Given this list of marker genes Klc1, Tlr3, Cbl, Smarcd1, Ptprj, Olfml3, Npepps, Tfdp2, Rbm47, Fam241a, Hsdl1, Lamtor1, Myo9a, Snai2, Tbx20, Oaz1, Fut8, Pkm, Xxylt1, Srf, Ddx24, Rtraf, Atp2b2, Grhl2, Lynx1, Aldoa, Foxk2, Mtm1, Sox6, Tmigd1, Arfip2, Ift70b, Phaf1, Exoc6b, Dr1, Mtf2, Slc1a5, Ipo5, Lrrc71, Ptbp2, Pam, Rad50, Ms4a2, Lef1, Rcn1, Fam53b, Mospd1, Fam163b, Hsf5, Jph1, Klb, Kalrn, Ogfod1, Slc25a5, Sh3rf2, Slc7a1, Leprot, Vamp3, Adam10, Slc25a35, Idh3a, P4ha1, Gys1, Slc16a1, Epb41l3, Synpo, Elovl1, Usp15, Dbndd2, Dagla, Zbtb4, Car10, D2hgdh, Rps6ka2 (NCBI Gene Id 436439), Calcr, Med1, here is a description of the gene set: from publication Chen Y, Wang X (PMID 31504780) Genes predicted to be targets of miRBase v22 microRNA mmu_miR_7211_3p in miRDB v6.0 with MirTarget v4 prediction scores > 80 (high confidence targets). Mouse Gene Set: MIR_7211_3P species: Mus musculus